Given this list of marker genes Fgf2, Cul3, Cxcr5, Garem1, Birc5, Cdc14a, Arf6, Fgf3, Vegfc, Rab11fip3, Ptn, Drd2, Vegfd, Racgap1, Pdgfd, Gipc1, Men1, Incenp, Drd3, Cspp1, Sstr5, Fgf6, Pgf, Cat, Hdgf (heparin binding growth factor), Svil, Tgfb1, Tas2r124, Cdc6, Wnk1, Igf1r, Fgf5, Kif14, Mrgprb1, Rxfp3, Il1b, Tas1r2, Pkn2, Tal1, Tas2r102, Rhoa, Vegfb, Pkp4, Nup62, Ybx1, Mdk, Btc, Prok1 (prokineticin 1), Shh (NCBI Gene Id 20423), Tgfa, Ect2, Poldip2, Vegfa, Cdc25b, Pdgfb, Cit, Tas2r121, Fgf8 (fibroblast growth factor 8), Pdgfc, Sirt2, Apc, Nkx3-1, Rab11a, Igf2, Kif23, Htr2b, Kif20b, Lbh, Cdc14b, Cdca8, Spast, Gkn1, Fgf7, Kif3b, Tgfb3, Aurkb, Fgf4, Thbs4, Fgfr2, Ereg, Chmp3, Map10, Fgf1, Prkce, Itgb1bp1, Cenpv, Il1a, Tgfb2, Cdc42, Pdgfa, Fgf9, Exoc7, here is a description of the gene set: studied in species Mus musculus Mouse Gene Set: GOBP_POSITIVE_REGULATION_OF_CELL_DIVISION Any process that activates or increases the frequency, rate or extent of cell division.